Given this list of marker genes ZAP70, RTN3, BMP1, ST3GAL6, GRIA2, CYFIP2, EVI2A, EFHD1, GSN, NCAM1, CTSS, PLD4, RBMX, CORO1A, SIRPA, KCNAB2, CD68, HSD11B1, RNF227 (NCBI Gene Id 284023), ZDHHC14, MAL, HDC, RGS14, GP1BB, RELN, CLEC4A, EVL, ACVRL1 (activin A receptor like type 1), PRKCB, PPP2R5A (NCBI Gene Id 5525), STMN1, TYROBP (NCBI Gene Id 7305), HSD17B8, CCL15, MLLT11, ITGB2, RGS10, CMA1, B4GALNT1, CD53, HBB, ROGDI, ADGRE1, CSF1R, CEBPD, ABR (ABR activator of RhoGEF and GTPase), ABLIM1, PAPSS2, COL11A2, PACSIN1, ADSS1, PPP3CA, CBX4, NHSL2, LY86, PGLYRP1, AP2A2, RNASEK, CTSB, GYPA, BIN1, NRP1, RFLNB, NIN, MPEG1, CD47, ARG2, LAT2, SLFN12, SLC11A1, PTPRC, GRINA, here is a description of the gene set: The transcriptional profiles of mouse embryonic, neural, and hematopoietic stem cells were compared to define a genetic program for stem cells. A total of genes are enriched in all three types of stem cells, and several of these genes are clustered in the genome. When compared to differentiated cell types, stem cells express a significantly higher number of genes (represented by expressed sequence tags) whose functions are unknown. Embryonic and neural stem cells have many similarities at the transcriptional level. These results provide a foundation for a more detailed understanding of stem cell biology. Genes depleted in embryonic, neural and hematopoietic stem cells. from publication Ramalho-Santos M, Yoon S, Matsuzaki Y, Mulligan RC, Melton DA (PMID 12228720) Human Gene Set: RAMALHO_STEMNESS_DN species: Mus musculus